Given this list of marker genes H2-M2, Synpo2, Pfkfb3, Tspan3, Arhgap22, here is a description of the gene set: from publication Cui A, Huang T, Li S, Ma A, Pérez JL, Sander C, Keskin DB, Wu CJ, Fraenkel E, Hacohen N (PMID 38057668) Mouse Gene Set: CUI_MIGDC_TSLP_RESPONSE_DN studied in species Mus musculus Cytokines mediate cell-cell communication in the immune system and represent important therapeutic targets. A myriad of studies have highlighted their central role in immune function, yet we lack a global view of the cellular responses of each immune cell type to each cytokine. To address this gap, the authors created the Immune Dictionary, a compendium of single-cell transcriptomic profiles of more than 17 immune cell types in response to each of 86 cytokines (>1,400 cytokine-cell type combinations) in mouse lymph nodes in vivo. A cytokine-centric view of the dictionary revealed that most cytokines induce highly cell-type-specific responses. For example, the inflammatory cytokine interleukin-1β induces distinct gene programmes in almost every cell type. A cell-type-centric view of the dictionary identified more than 66 cytokine-driven cellular polarization states across immune cell types, including previously uncharacterized states such as an interleukin-18-induced polyfunctional natural killer cell state. Genes negatively differentially expressed in cell type: MigDC (migratory dendritic cell) upon treatment with cytokine: TSLP in mouse lymph nodes in vivo.